Given this list of marker genes Prdm9, Ccdc87, Lhfpl2, Park7, Prss37, Cfap69, here is a description of the gene set: species: Mus musculus Mouse Gene Set: GOBP_POSITIVE_REGULATION_OF_FERTILIZATION Any process that activates or increases the frequency, rate or extent of fertilization.